The following is a description of a gene set: Mouse genes annotated to increased prostate intraepithelial neoplasia incidence (MP:0009219) retrieved from the Mouse Genome Informatics database via MouseMine studied in species Mus musculus from publication Motenko H, Neuhauser SB, O'Keefe M, Richardson JE (PMID 26092688) Mouse Gene Set: MP_INCREASED_PROSTATE_INTRAEPITHELIAL_NEOPLASIA_INCIDENCE, and this is the list of marker genes: Tgfbr2, Cop1, Eaf2, Pik3ca, Eaf1, Ctnnb1, Acp3, Rxra, Scrib (NCBI Gene Id 54559), Apc, Brca2, Ldah, Nkx3-1, Nbn, Zfhx3, Msmb, Pten, Kras